Given this list of marker genes AIPL1, CACNA1F, CACNB4, RRH, LRIT1, PDE6B, ABCA4, TULP1, GUCA1ANB-GUCA1A, GUCA1A, NMT2, OPN1MW3, PLEKHB1, GUCY2F, ATP8A2, PDE6C, GNA11, GNAT1, SEMA5B, SLC24A2, OPN5, OPN1LW, GNGT2, RBP4, PDC, GJA10, CDS1, ASIC2, GNGT1, GPR52, RCVRN, SAG, EYS, ROM1, RP1, CRB1, GNAT2, OPN3, RGS9BP, CAMKMT, CNGB1, RGR, OPN1MW, PNPLA2, CABP4, PITPNM1, GPR88, GNAT3, NMT1, GRK7, BEST1, REEP6, CCDC66, PRPH2, OPN1SW, GNAQ, ELOVL4, GUCY2D, TTR, RPE65, CACNA2D4, TRPC3 (transient receptor potential cation channel subfamily C member 3), CEP250, GRM6, UNC119, GRK1, NR2E3, OPN4, GUCA1B, PCP2, OPN1MW2, RHO, FECH, SLC24A4, GRK4, here is a description of the gene set: Human Gene Set: GOBP_DETECTION_OF_LIGHT_STIMULUS The series of events in which a light stimulus (in the form of photons) is received and converted into a molecular signal. species: Homo sapiens